Given this list of marker genes Dolk, here is a description of the gene set: Reactome Pathway: Synthesis of dolichyl-phosphate This event has been computationally inferred from an event that has been demonstrated in another species.<p>The inference is based on the homology mapping from PANTHER. Briefly, reactions for which all involved PhysicalEntities (in input, output and catalyst) have a mapped orthologue/paralogue (for complexes at least 75% of components must have a mapping) are inferred to the other species. species: Mus musculus electronically inferred by orthology from the curated human pathway part of: Synthesis of substrates in N-glycan biosythesis